Given this list of marker genes IDUA, RSPRY1, BMPER, POR, PCNT, PTH1R, FGFR2, BGN, here is a description of the gene set: species: Homo sapiens Human Gene Set: HP_NARROW_PELVIS_BONE Narrow pelvis bone Reduced side to side width of the pelvis.